The following is a description of a gene set: species: Homo sapiens Human Gene Set: GOBP_ERBB_SIGNALING_PATHWAY The series of molecular signals initiated by binding of a ligand to a member of the ERBB family of receptor tyrosine kinases on the surface of a cell, and ending with the regulation of a downstream cellular process, e.g. transcription., and this is the list of marker genes: RNF126, CEACAM1, SNX6, ABL1, SHC3, ERBB2, PTPN2, VIL1, PTPN3, PTPN11, RBPJ, PTPN18, RHBDF1, SH3TC2, CHMP6, CPNE3, CTNNB1, MVB12A, GAREM1, SNX5, NPPA, NRG2, SPRY2, PIGR, MAPK1, CUL5, AREG, PLAUR, ERRFI1, NEU3, MAP2K1, SOS1 (NCBI Gene Id 7838), EGF (epidermal growth factor), DUSP3, RALA, MAP2K2, FBXW7, ERBB3, GAB1, NRG4 (NCBI Gene Id 145957), SHKBP1, IFI6, ERBB4, ADRA2A, FER, GRB7, AGT (angiotensinogen), FASLG, HDAC6, RAF1, NRG1, ZFYVE28, SPG21, AFAP1L2, SRC, EFEMP1, TSG101, HAP1, PLCG1, PTK2, BRAF, ZGPAT, PIK3C2A, SOCS4, PDE6H, PLCE1, NUP62, FAM83B, WDR54 (WD repeat domain 54), EGFR, CRIPTO, ADAM17, RALB, MIR21, AQP5-AS1, RHBDF2, TGFB1 (NCBI Gene Id 7040), PTPRR, CNOT9, GRB2, GPRC5A, SHC1, MAPK3, MIR29A, PTPRJ, SOCS5, RNF115, LGMN, REPS2, ARF4 (ADP ribosylation factor 4), CCDC88A (coiled-coil domain containing 88A), ERBIN, CBLC, PDE6G, HIP1, MIR133A1, SLC30A10, VPS25, MVP, PRICKLE1 (NCBI Gene Id 144165), PTPN12, EREG, RAB7A, MYOC, EPGN, CBLB, HBEGF, ITGA1, KIF16B, NRG3, AGR2, NCK2, CAMLG, BCAR3, PTK6, DGKD, GPER1 (NCBI Gene Id 2852), STUB1, NPR2, IQGAP1, TGFA, DBX2, HIP1R, DAB2IP, DGKQ, SOX9, BTC, SH3GL2, PTK2B, ACP4, ABL2, CDH13, RTN4, MVB12B, PIK3CA, AKT1, MMP9 (NCBI Gene Id 4318), CBL, FAM83A, PDPK1, BCAR1